The following is a description of a gene set: Human Gene Set: chr1q25 species: Homo sapiens, and this is the list of marker genes: SOAT1, NCF2, MORF4L1P7, AXDND1 (NCBI Gene Id 148436), CRYZL2P, RGS8, CRYZL2P-SEC16B, RC3H1-IT1, TRMT1L, C1orf220, RN7SKP160, DHX9-AS1, EDEM3, C1orf21, HMCN1, COP1, RNA5SP72, LINC01732, LAMC2, TEDDM2P, IER5, LAMC1, CEP350, ZNF648, LINC01657, ARPC5, GS1-279B7.1, NMNAT2, GAS5, RPL22P24, LINC01686, RN7SL230P, PRDX6-AS1, PAPPA2, RABGAP1L-IT1, IVNS1ABP, RABGAP1L-AS1, ANKRD45, RC3H1, KLHL20, TOR1AIP2, SETP10, PTP4A1P7, STX6, COX5BP8 (NCBI Gene Id 100859925), COLGALT2, ENSG00000285910, MR1, ANGPTL1, TDRD5, LINC01633 (long intergenic non-protein coding RNA 1633), EIF4A1P11, RNU6-307P, GAS5-AS1, C1orf21-DT, SEC16B, NDUFAF4P4, TEX35, KIAA0040, TEX50, TOR3A, ABL2, SWT1, RPS29P5, TSEN15, LINC02816, RNA5SP67, CACNA1E, NPHS2, ENSG00000273629, RABGAP1L-DT, LINC02818, TNR-IT1, OVAAL, LINC01688, BANF1P4, RNF2, LINC01699, GLUL, SCARNA3 (NCBI Gene Id 677679), TEDDM1 (transmembrane epididymal protein 1), GOT2P2, YPEL5P1, MIR3121, LINC01350, SMG7, ENTR1P2, RGS16 (regulator of G protein signaling 16), HMGN1P4, RNU2-12P, GPR52, RPL30P1, RC3H1-DT, SMG7-AS1, ASTN1, LINC01741, XPR1 (NCBI Gene Id 9213), SHCBP1L, DHX9, RNU6-152P, RNU6-41P, SERPINC1, RNASEL, LINC00272, FAM163A, COP1-DT, RNU7-13P, LHX4, KIAA1614, NPL (N-acetylneuraminate pyruvate lyase), RASAL2-AS1, RABGAP1L, MIR488 (microRNA 488), TOR1AIP1, ENSG00000287697, EIF1P3, RNA5SP68, RNA5SP69, MEF2AP1, LINC01645, LINC02803, ENSG00000300706, NIBAN1, RPSAP16, RNU7-183P, PTPN2P1 (NCBI Gene Id 650902), PRDX6, SLC9C2, APOBEC4, RNA5SP70, FTH1P25, CLEC20A, ENSG00000201619, QSOX1, VDAC1P4, LAMC1-AS1, RNU5F-2P (RNA, U5F small nuclear 2, pseudogene), LINC01344, RGL1, SNORA63, RPL5P5, RPS29P4, CENPL, RALGPS2-AS1, GS1-204I12.4, CACYBP, MCRIP2P2, KIAA1614-AS1, ENSG00000298667, MRPS14, TNN, BRINP2, DARS2, ZBTB37, TNFSF4, MIR4424, RPS3AP8, TNR, TNFSF18, RGSL1, RALGPS2 (NCBI Gene Id 55103), FAM20B, ACBD6 (NCBI Gene Id 84320), RPS27P7, HNRNPA1P54, RN7SL654P, RN7SKP229, RASAL2 (RAS protein activator like 2), KRT18P28